Given this list of marker genes PKD2, TMEM185A, PGM5, CX3CL1, GSTM3, PALLD, SH3BGRL, KCNJ3, CLIC6, FOXQ1, DDR2, ITIH5, SCGB3A1, COL4A1, PRELP (proline and arginine rich end leucine rich repeat protein), BNIP2, TSPAN18, PRSS23 (serine protease 23), DNM3OS (NCBI Gene Id 100628315), ITGB6, PDK4, CLMP, COL16A1, DNAAF9, FHOD3, MELTF, CHRDL1, SEMA6D, ABCC3, SVIL, NAP1L1 (NCBI Gene Id 64165), LDHB, NID1, ALDH3A2, CYS1, CELSR2, ENO2, DUOX1, TGFB1I1, ADAM33, ATXN1-AS1, SRSF11, PMP22, TSC22D3, ICA1L, KRT15, KRT13, TTC28, NTN4, DTNA, FERMT2, GPD1L, SLC47A1, KANK2, CLIP4, AOPEP, FYN, SDC1, PPP3CC, TPM2, GPR155, COL7A1, VCL, COL5A1, RAB34, FZD7, SCRG1, UBA7, SALL3, KLHL29, PLPP3, LTBP1, ARHGEF40, S100A6, GRK5, EPAS1, NCAM1, TRAF5, MAGI2-AS3, LMAN1L, GALNT10, SYNGR1, FGFR2, H3-3B, VAV3, GJC1, LMOD1, C1QTNF1 (C1q and TNF related 1), HOXD10, HOXD13, EFEMP2, LINC00844, SERPINA5, AQP3, TRIM29, CD248, GPC6, EEF2K, MYO15B, GRHL1, SLCO3A1, C12orf75, MEG3, STARD4, PPIC, OPTN, STOX2, TGFB3, PCAT4, ZNF398 (NCBI Gene Id 57541), COL4A2, KRT14, ST6GALNAC2, SORBS2, ITGA2, PRRX1 (paired related homeobox 1), RBP1, CARMN, AKAP12, C1S, SCRN1, FHDC1, NLRP1, LAMB1, CAVIN1, CRIM1 (NCBI Gene Id 51232), DES, ANXA2, SEMA3E, NHSL2, NNT, DPYSL3, CTSB, VAMP5, DST, NAV2, DMD, WIF1, PGAP4, ITGA9, VANGL2, ZCCHC14, TGFB2, SLC14A1, C14orf28, HLA-E, JAZF1, TUBB6, SSX2IP, AOC1, CPLX3, CLIC4, C2orf88, MYOCD (NCBI Gene Id 93649), SNORD123, KITLG, MSRB3, CAV1, BCL2, TUBA1A, SLC16A14, CDC42EP3, FOXF1, SH3PXD2B, GSTA1, SPEG, WFDC1, KRT23, EFS, PCDH7, TNS4, PDLIM1, IRAG1, ZNF204P, FGFR1, GAS6, TMEM237 (NCBI Gene Id 65062), GYPC, SLC18A2, PEX14, NR3C2, MYZAP, ZBTB47, NDNF, MR1, MME, ADCY4, FADS1, DOK4, LSAMP, COCH, CACHD1, MFSD2A, COL14A1, FLRT3, FCGBP, UBE2QL1, DAB2IP (DAB2 interacting protein), FRMD6, C1R (NCBI Gene Id 791254), PDLIM4 (PDZ and LIM domain 4), SLC4A11, DKK3, MYH11, PNMA8A, DMKN, PGM5-AS1, RARRES2, OSR2, HLF, RCAN2, TMEM100, FBLN5, TBC1D1, STOM, PPP1R12A, TRIP6, PLAGL1 (NCBI Gene Id 5325), PRIMA1, PLAU, CYP4F8, DSC3, PIK3R1 (NCBI Gene Id 5295), VEGFA, DSE, TFCP2L1, ATP2B4, ECRG4, SNAI2, SRPX, MARVELD1, PLCL1, RBM33, CLU, ZNF536, WFS1, TCEAL2, PER3, LONRF3, ANK2 (ankyrin 2), FHL1, ANO1, MRAS, TACC1, GSTM1, EPHA2, LPAR1, GPRASP1, PTGER2, KLF11, HEPH, WFDC2, KRT19, SMOC1, TUB, RHOJ, BEND5, PLEKHA2, KLF8, KCNMA1, SLC24A3, AOC3, EOGT, PLLP, ACTA2, EPHA7, ANKDD1A, CYP4B1, TGFBR3, SEMG2, ADGRA2, MRGPRF, SCUBE2, P3H3, EFEMP1 (EGF containing fibulin extracellular matrix protein 1), S100PBP, ADCY9, MYOF, TLE2, GBP2, CRABP1, ZNF75D (NCBI Gene Id 91310), ZNF827, FCHSD2, AHSA2P, MET, ITGA1, MAP1B, ARMCX4, CYP3A7, SCGB1A1, SGPP2, CAV2, NELL2, CSRP1, NEFH, EHD2, GABRE, ACTG2, GSTP1 (NCBI Gene Id 2950), CIBAR1, SLFN5, IGF2, TIMP2, TIMP3 (NCBI Gene Id 7078), SERPINF1 (serpin family F member 1), MCAM, PREX2, SLC25A12, HSPG2, HSPB8 (NCBI Gene Id 8097), TTLL3, COL6A1, GPR87, SPATA18, ATP1A2, MIR205, FAM83D, LYST, RBPMS, PDGFD, FLNA, TNS1, RIMKLB, ETS2, CPAMD8, EPB41L3, NHS, S100A4, GPX2, LAYN, COL1A2, DDB2, SH3GLB1, WDR33, ANKRD35, ANGPTL2, INPP1, IL33, ACOX2, COL27A1, TRPC4, PCDH9, PRICKLE2, MYL9, GATA3, SCPEP1, CHST2, TP63, COL4A6, LAPTM4B, ACAA2, ENAH, BDH2, PTGDS, KRT17, U2SURP, MYLK, FEZ1, PDE4A, LAMA4, FLNC, KSR1, DPT, CFL2, SGCE, ID4, SOSTDC1, ACKR3, SEMG1, SYNPO2, EVA1C (NCBI Gene Id 59271), EHF, NPR2, LAMB2, CCK, INAVA, TAGLN, RAP1A, TMT1A, CNRIP1, FBN1, CRABP2, TMEM200B, SPARC, BTN2A1, CORO1C, MASP1, CEACAM6, C2orf68, ISYNA1, CFD, CCDC136, AEBP1, CXCL17, SORBS1, PRRT2, FBXO2, RBMS1 (NCBI Gene Id 5937), ZNF395, CCDC50, SBSPON, CERK, MEIS1 (Meis homeobox 1), PARP6, MUC4, ARL10, SRD5A2, AJUBA, GPLD1, GPR161, ACACB, TSLP, TRO, NBL1 (NCBI Gene Id 4681), KIRREL1, SSPN, SLMAP, LCAT, RBP4, AHNAK2, MRC2 (NCBI Gene Id 9902), MIR100HG, PDGFC, WDR1, FBXO17, UNC5B, TPM1, ASB3, TNRC6A, ADAMTS5, SH3PXD2A, ALDH2, HSPB1, TPST1, TUBA4A, RASL12, ANXA2P2 (NCBI Gene Id 304), KRT5, LAMB3, FGD5, CSRP2, TMEM35A, PGF, GJA1, KCNJ8, KRT7, AKR1B1, KIT, EYA4, DENND2B, NEURL1B, CRISPLD2, CCND2, NEMP1, CHN1, LGALS1, RAVER2, MECOM, COL9A1, CRYAB, PGR, BTG3, PODN, VSTM4, OTULIN, NEXN, ARHGAP23, CAPG, GPM6B, GNAL, MXRA7, CALD1, WNT2B, AMY1A, PPP1R12B, ANGPTL1, ROBO1, ID1, MPZL2, ITGA8 (integrin subunit alpha 8), SLC6A6, SPON1, TXNL1, SNX7, CASP1, CYP3A5, GATM, LPCAT4 (lysophosphatidylcholine acyltransferase 4), GLIS1, ECHDC1, COL13A1, FXYD6, PLEKHH2, PENK, here is a description of the gene set: Genes down-regulated in prostate cancer samples. studied in species Homo sapiens Human Gene Set: LIU_PROSTATE_CANCER_DN Prostate cancer is the most commonly diagnosed noncutaneous neoplasm and second most common cause of cancer-related mortality in western men. To investigate the mechanisms of prostate cancer development and progression, we did expression profiling of human prostate cancer and benign tissues. We show that the SOX4 is overexpressed in prostate tumor samples compared with benign tissues by microarray analysis, real-time PCR, and immunohistochemistry. We also show that SOX4 expression is highly correlated with Gleason score at the mRNA and protein level using tissue microarrays. Genes affected by SOX4 expression were also identified, including BCL10, CSF1, and NcoA4/ARA70. TLE-1 and BBC3/PUMA were identified as direct targets of SOX4. Silencing of SOX4 by small interfering RNA transfection induced apoptosis of prostate cancer cells, suggesting that SOX4 could be a therapeutic target for prostate cancer. Stable transfection of SOX4 into nontransformed prostate cells enabled colony formation in soft agar, suggesting that, in the proper cellular context, SOX4 can be a transforming oncogene. from publication Liu P, Ramachandran S, Ali Seyed M, Scharer CD, Laycock N, Dalton WB, Williams H, Karanam S, Datta MW, Jaye DL, Moreno CS (PMID 16618720)